Given this list of marker genes TCF3, BCL2, GPR183, CD40, BST1, PRLR, IL4, TLR9, PTPRC, MEF2C, BTK, TNFRSF13C, SLC39A10, TICAM1, NFATC2, BCL6, TLR4, CHRNB2, CD320, TIRAP, IRS2, ATAD5, VAV3, IL7, CDKN1A, NCKAP1L, IL2, CD74, TFRC, CLCF1, CD38, ADA, IL21, TNFSF13, MIF, CD81, TNFSF13B, SASH3, IL13, IL5, WNT3A, FCRL3, TNFRSF4, PELI1, EPHB2, CARD11, BMI1, here is a description of the gene set: Any process that activates or increases the rate or extent of B cell proliferation. studied in species Homo sapiens Human Gene Set: GOBP_POSITIVE_REGULATION_OF_B_CELL_PROLIFERATION